The following is a description of a gene set: Human Gene Set: CHIARADONNA_NEOPLASTIC_TRANSFORMATION_KRAS_CDC25_UP from publication Chiaradonna F, Sacco E, Manzoni R, Giorgio M, Vanoni M, Alberghina L (PMID 16607279) Genes up-regulated in NIH3T3 cells (fibroblasts) transformed by activated KRAS vs those reverted to normal cells upon over-expression of a dominant negative form of CDC25. species: Mus musculus Mutational activation of ras genes is required for the onset and maintenance of different malignancies. Here we show, using a combination of molecular physiology, nutritional perturbations and transcriptional profiling, that full penetrance of phenotypes related to oncogenic Ras activation, including the shift of carbon metabolism towards fermentation and upregulation of key cell cycle regulators, is dependent upon glucose availability. These responses are induced by Ras activation, being specifically reverted by downregulation of the Ras pathway obtained through the expression of a dominant-negative Ras-specific guanine nucleotide exchange protein. Our data allow to link directly to ras activation the alteration in energy metabolism of cancer cells, their fragility towards glucose shortage and ensuing apoptotic death., and this is the list of marker genes: ACOT7, PCLAF, GGCT, ZNF706, RASA1, KITLG, TMSB4X, APCDD1, HMGA2, PSMB5, VAMP5, CYTIP, CSRP2, KCNN4, SEMA5A, SLC66A3, CD9, TSPO, CRABP1, CCND1, GADD45A (growth arrest and DNA damage inducible alpha), TES, RAB7A, TGFBI (transforming growth factor beta induced), LAPTM4B, EIF2S1, CAPG, ITGB7, BBLN, CDKN1A, SSNA1, GPC1, CASP3, RGS16, SELENOF, ITGA6, EVI2A, FUT8, CTSV, GJA1, NGEF, SERPINA1, PDGFA, SEMA7A, NUPR1, GDNF (NCBI Gene Id 2668), ANGPTL2, AREG, SPTSSA, CLIC1, UPP1, PMF1, PLP2, ANKH (NCBI Gene Id 7995), WWTR1, SPP1, POLD4 (DNA polymerase delta 4, accessory subunit), RAD51, FXYD5